Given this list of marker genes IL1RN, RELA, GABARAPL1, CXCL3, CDKN1A, MMP14, FN1 (NCBI Gene Id 2335), TRAF1 (NCBI Gene Id 7185), RAC1, MT3, TNFAIP8, IL32, STAT5A, CD83, CCL5, SERPINE1, BIRC2, MMP1, MAP2K3, IL15, MAPK9, RARRES1, MMP9, NFKBIA, ERCC1, LITAF, MTSS1, GBP1, EGFR, NPR1, TAP1, ARHGDIA, IL6, TNIP1, CXCL8 (C-X-C motif chemokine ligand 8), GADD45A, TNFAIP2, KRT7, IL1B, CSF2, PTX3, NFKB1, IL7R, BCL2A1, SERPINB2, TNC, PLAU, ITGB6, CYP27B1 (cytochrome P450 family 27 subfamily B member 1), TNFAIP6, VEGFA, BMP2, CDH3 (NCBI Gene Id 1001), ARHGDIB, SPRR1B, ICAM1 (NCBI Gene Id 3383), TIAM1, SOD1, IRF1, SOD2, CD9, WFDC2, PLAT, SLC7A2, SAA1, VIM, EFNA1, CCNH, TNFAIP3, TNF, GPRC5B, CXCL6, PNRC1, XPC, CXCL11, WNT5A, KRT10, RND3, KRT14, CCL20, CXCL10, CFLAR, ESM1, GSTO1, here is a description of the gene set: Human Gene Set: HINATA_NFKB_TARGETS_KERATINOCYTE_UP Genes up-regulated in primary keratinocytes by expression of p50 (NFKB1) and p65 (RELA) components of NFKB. from publication Hinata K, Gervin AM, Jennifer Zhang Y, Khavari PA (PMID 12673201) NF-kappa B regulates normal and pathological processes, including neoplasia, in a tissue-context-dependent manner. In skin, NF-kappa B is implicated in epidermal homeostasis as well as in the pathogenesis of squamous cell carcinoma; however, its function in the underlying mesenchymal dermis has been unclear. To gain insight into NF-kappa B roles in these two adjacent cutaneous tissue compartments, NF-kappa B effects on expression of genes were determined in epidermal keratinocytes and dermal fibroblasts. Although NF-kappa B induced proinflammatory and antiapoptotic genes in both settings, it exhibited divergent effects on growth regulatory genes. In keratinocytes, but not in fibroblasts, NF-kappa B induced p21(CIP1), which was sufficient to inhibit growth of both cell types. Levels of growth inhibitory factor (GIF), in contrast, were increased by NF-kappa B in both settings but inhibited growth only in keratinocytes. These findings indicate that transcription factors such as NF-kappa B can program tissue-selective effects via both differential target gene induction as well as by inducing common targets that exert differing effects depending on cellular lineage. species: Homo sapiens